The following is a description of a gene set: studied in species Homo sapiens Human Gene Set: GOCC_TRANSCRIPTION_FACTOR_TFIIH_HOLO_COMPLEX A complex that is capable of kinase activity directed towards the C-terminal Domain (CTD) of the largest subunit of RNA polymerase II and is essential for initiation at RNA polymerase II promoters in vitro. It is composed of the core TFIIH complex and the TFIIK complex., and this is the list of marker genes: GTF2H2C_2, ERCC3, GTF2H1, GTF2H2C, GTF2H3, GTF2H4, MNAT1, GTF2H2, CDK7, MMS19, GTF2H5, CCNH, ERCC2